The following is a description of a gene set: studied in species Homo sapiens The malate-aspartate shuttle (MAS) is a redox process that supports oxidative pathways in the cytosol, and reductive potential in mitochondria. The mitochondrial succinate dehydrogenase (SDH) reaction provides reducing equivalents (electrons) for the respiratory electron transport, with the NADH needed to reduce malate coming from cytosolic processes. There is no NADH equilibrium between cytosol and mitochondria: cytosolic NADH/NAD+ ratio is 0.001, while in mitochondria, it is 0.1. The MAS creates this NADH gradient by reducing oxaloacetate (OA) to malate (MAL), catalyzed by cytosolic MDH1, and exchanging cytosolic MAL with mitochondrial 2-oxoglutarate (2OG, 2-KG), catalyzed by SLC25A11. At the same time, aspartate (L-Asp) gets exported and transaminated to glutamate (L-Glu), which subsequently gets coimported with a proton and transaminated back. In summary, mitochondria take up one proton and one reducing equivalent. The proton import by SLC25A12/13 is irreversible, so the MAS always runs in one direction. Hence, the mitochondrial outward proton-motive force drives the MAS toward cytosolic NADH oxidation. Defects in any of the reactions of this pathway lead to cytosolic NAD+ scarcity, affecting glycolysis, L-Glu, and L-Ser biosynthesis, as well as L-Asp availability. Neurotransmission in the CNS specifically needs L-Asp and L-Glu, and mutations in proteins catalyzing MAS reactions are commonly associated with early infantile epileptic encephalopathy. part of: Respiratory electron transport Reactome Pathway: Malate-aspartate shuttle, and this is the list of marker genes: SLC25A12, MDH1, SLC25A18, SLC25A13, MDH2, GOT2, SLC25A11, SLC25A22, GOT1